Given this list of marker genes Smad4 (SMAD family member 4), Notch1, Mdm2, Acvr1 (activin A receptor, type 1), Hey2, Zfpm1, Adamts19, Heyl, Bmpr1a, Bmpr2, Tgfbr2, Twist1 (twist basic helix-loop-helix transcription factor 1), Zfpm2, Tbx5, Mdm4, Hey1, Ccn1, Dchs1, Bmp2, Tgfb2, Gata4, Smad6, Slit3, Axin2, Efna1, Sox4, Olfm1, Naglu (alpha-N-acetylglucosaminidase (Sanfilippo disease IIIB)), here is a description of the gene set: Mouse Gene Set: GOBP_ATRIOVENTRICULAR_VALVE_MORPHOGENESIS studied in species Mus musculus The process in which the structure of the atrioventricular valve is generated and organized.